Given this list of marker genes JPH2, TRDN, BAG5, JPH4, JPH3 (junctophilin 3), JPH1, here is a description of the gene set: studied in species Homo sapiens Human Gene Set: GOCC_JUNCTIONAL_MEMBRANE_COMPLEX Complex formed in muscle cells between the membrane of the sarcoplasmic reticulum and invaginations of the plasma membrane (T-tubules).